Given this list of marker genes SETX, TRAF3IP3, MSH3, TMC6, PIP4P2, TEX264, YPEL3, EVA1B, CCS, PATJ, CENPT, OXCT1, S100A10, DSEL, HADHB, ZBTB25, CDK2AP2, DPH2, ZNF251, LRRC8A, KCNMB4, TANC1, RFTN2 (raftlin family member 2), MPPE1, PAQR7, RASGRP1, RPL5, RHOH, ADD1, NOP10, ZDHHC15, TMEM50A, EXO5, MRPL58, TUSC3, ARAP1, MAT2B, IFT80, ACAP1, ELOVL6, RFFL, CRBN, MBP, ZNF260, PTPRA, FYN, PRKCZ, RPLP2, ATP2A3, SP110, TOM1, PIGX, HADH, NT5C3B, TCF12, SLC25A12, DOCK2, PINK1, SLCO3A1, SPO11, SGCB, SEPTIN9, ATPAF1 (NCBI Gene Id 64756), BTBD19, B3GNT5, SELL, HOOK1, DAXX, SNAP47, DGKE, PGK1, MAGED2 (NCBI Gene Id 10916), TBCEL, GMFG, NCK1, TGFBR2, RASA3, PDHA1, NAA10, PSTK, FOXO1, SIAH1, GBP7, DYRK2, DAD1, FRMD6, DZIP1, HDAC7, GALNT10, PEX5, ITM2A, PTGR3, WASHC3, PYCR2, DDX1, NLE1, IL27RA, IKZF1, PPP1R13B, CASP8, RECK (NCBI Gene Id 8434), UNKL, ZNF639, CISH, NAT1, CD4, CBX4, EIF3H, CD200, FRMD8, SPATA6, KRTCAP2, IRF4, ITGB7, FLI1, FOCAD, CTSE, RNF167, GBP6, SIGIRR, SMC4, IGF2BP2, TPRG1L, MLLT6, ARL2BP, XKRX, TMEM164, RNF19A, RFTN1, IFIT1, PLEC, C5orf34, TUBA4A, PFKP, ACY1, ARV1, LDB1, PPARGC1B, METTL26, NLK, NMNAT3, CYTH1, SATB1 (SATB homeobox 1), CHCHD10, MIF, ARL4C (NCBI Gene Id 10123), METTL9, MAN1A2, GTF2I, NCKAP5L, RASAL3, LNPEP, TBC1D10C, MTHFD1L, GALNT2, CHURC1, CMKLR1, RGS10, FBXL14, MELTF, STAMBPL1, VIPR1, PDCD2, ZSCAN25, BICDL1, MYL11, UTRN, EMC9, PHC2, IL2RG, ICAM2, LGALS9B, FAM117A, PYROXD1, ADD3, ALDH6A1, PITPNC1 (NCBI Gene Id 731962), XRN2, PGLYRP2, USP24 (NCBI Gene Id 388634), AKAP12, SARAF (NCBI Gene Id 95251), RCBTB2, GBP2, ARHGAP31, SNX2, C12orf57, ARHGAP45, AP1G2, SSBP3, CDKN2D, RALGPS2, GALNT7, BOLA2 (bolA family member 2), IMPDH1, CCDC71, CDC25B, RIPK3 (receptor interacting serine/threonine kinase 3), TLE5 (NCBI Gene Id 166), CBX7, here is a description of the gene set: Goals/objectives: to identify various gene expression in B cell subsets derived from human PBMC and cord blood Human Gene Set: GSE17186_NAIVE_VS_CD21LOW_TRANSITIONAL_BCELL_CORD_BLOOD_UP from publication Suryani S, Fulcher DA, Santner-Nanan B, Nanan R, Wong M, Shaw PJ, Gibson J, Williams A, Tangye SG (PMID 19965666) studied in species Homo sapiens Genes up-regulated in B lymphocytes from cord blood: naïve versus transitional CR2.